The following is a description of a gene set: Human Gene Set: GOMF_C_PALMITOYLTRANSFERASE_ACTIVITY species: Homo sapiens Catalysis of the transfer of a palmitoyl group to a carbon atom on the acceptor molecule., and this is the list of marker genes: SPTLC3, SPTLC2, SPTSSA, SPTSSB, SPTLC1 (NCBI Gene Id 3302)